Given this list of marker genes Mos, Spc25, Cdca8, Anapc15-ps, Numa1, Klhl22, Ska3, Tpr, Ska1, Anapc11, Cdc16, Knl1, Psmg2, Birc5, Spc24, Fbxo5, Khdc3, Mad1l1, Ccnb1, Rb1, Anapc7, Ttk, Ube2c, Atm, Bub3, Ncaph2, Cep192, Aurkb, Cdk5rap2, Lcmt1, Nsmce2, Xrcc3, Cenpe, Ncaph, Bub1, Arhgap33os, Chfr, Sycp3, Cul3, Zfp207 (zinc finger protein 207), Ndc80, Dusp1, Ncapg2, Ncapd3, Mad2l1, Nuf2, Ncapd2, Cdc23, Prap1, Anapc15, M1ap, Incenp, Haspin, Ccnb1-ps, Pcid2, Cdc20, Bub1b, Smarcad1, Prpf4b, Cenatac, Anapc5, Plk1, Espl1, Rad21, Plscr1, Tex14, Ik, Ppp2r1a, Spdl1, Mad2l1bp, Usp44 (ubiquitin specific peptidase 44), Csnk2a2, Top2a, Zwilch, Apc, Kntc1, Csnk2a1 (casein kinase 2, alpha 1 polypeptide), Zwint, Mapk15, Smc4, Zw10, Smc2, Dync1li1, Trip13, Dis3l2, Recql5, Gen1, Top3a, here is a description of the gene set: Mouse Gene Set: GOBP_CHROMOSOME_SEPARATION The cell cycle process in which paired chromosomes are detached from each other. Chromosome separation begins with the release of cohesin complexes from chromosomes; in budding yeast, this includes the cleavage of cohesin complexes along the chromosome arms, followed by the separation of the centromeric regions. Chromosome separation also includes formation of chromatid axes mediated by condensins, and ends with the disentangling of inter-sister catenation catalyzed by topoisomerase II (topo II). species: Mus musculus